Given this list of marker genes Gm12643, Cyp2j11, H3f5, Hspe1-ps6, 4930551L18Rik, Tek, Gm12695 (NCBI Gene Id 638645), Cyp2j8, Gm12633, 9530080O11Rik, Gm27521, Elavl2, Gm12694, Fggy, Cyp2j15-ps, Gm12671, Gm12650, Cyp2j9, Gm12634, Gm12707, Caap1, Junos, Gm12637, Gm12641, Gm12638, Cyp2j7, Gm12703, Gm830, Gm12654, Gm22605, Gm25004, Gm12639, Gm12669, Mysm1 (myb-like, SWIRM and MPN domains 1), Gm25244, Mir872, Gm12632, Gm12653, Izumo3, Gm12655, Ift74, Gm12670, Cyp2j6, Gm12708, Cyp2j13, Gm12693, Gm12636, Plaa (NCBI Gene Id 52374), Hook1, Jun, Gm12635, Tusc1, Gm12704, Gm12648, Gm23443, Eqtn, Cyp2j12, Lrrc19, Zfp352, Gm12642, Cyp2j5, Mir6402, Larp7-ps, 4930577H14Rik, Cyp2j14-ps, Gm12656, Gm12667, Gm12647 (predicted gene 12647), Gm12644, here is a description of the gene set: Mouse Gene Set: chr4C5 species: Mus musculus